The following is a description of a gene set: studied in species Mus musculus ERK/MAPK targets Mouse Gene Set: REACTOME_ERK_MAPK_TARGETS, and this is the list of marker genes: Dusp4, Rps6ka3, Dusp6, Vrk3, Rps6ka1, Mapk1, Ppp2cb, Mapk11, Dusp3, Dusp7, Rps6ka2, Ppp2r1b, Mapk7, Mapk14, Ppp2ca, Ppp2r5d, Rps6ka5, Ppp2r1a, Mapk3